Given this list of marker genes ISL1, P2RY1, CPA3, CYP2C18, CYP1B1, GCG, CYP2D6, PLA2G6, SLC8B1, H6PD, ADCY5, FFAR4, HSD3B2, SOX8, GNA11, MPC2, AGT, BBS1, HTR2C, CRY1, AIMP1, SNX19, C1QTNF12, CFTR, DGAT1, NIBAN2, TM7SF3, PER2, PLEKHA1, HSD17B2, CAMK2G, HID1, CHST10, CPE, BMP2, WNK4, SIRT3, CELA2A, VAMP8, TRPM5, GLUD1, HSD17B6, TRPA1, OXCT1, CHRM3, CGA, RAB11FIP5, RDH14, KCNQ1, KLK6, SIDT2, GCNT4, UGT2B17, GALR1, CDK16, TIPARP, LRP5, LHCGR, GNAO1, FOXE1, NOS2, DHRS9, KCNK9, FGFR1, TARDBP, ADH6, APLN, PCSK4, LEP, ASMT, CLCN2, LRRC8A, SNX4, TMF1, PDE8B, PCSK5, NDST2, MAFA, POMC (NCBI Gene Id 5443), FOXA2, GIP, SHH, HSD17B10, HSD17B3, SLC5A5, HSD17B4, AFP, ALDH8A1, EPHA5, DHRS2, ARNT, ITSN1, RDH12, GPLD1, SLC17A4, RBP4, PDX1, UGT1A3, UGT1A9, WNT4, SLC7A8, UGT1A1, OSBP, DIO2, CTSB, RDH8, MBOAT4 (membrane bound O-acyltransferase domain containing 4), AGTR1, TUNAR, PAX8, ATP1A1, NMU, ANO1, PPARG, C2CD2L, RPH3AL, RAPGEF3, SLC2A2, DIO1, GNAS, DUOX2, SLC16A1, EDN3, PASK (PAS domain containing serine/threonine kinase), ACVR2B, TUBB1, IL4I1, PPARD, CYP11B2, ZMPSTE24, IL1B, SULT1A3, ORAI1, SNAP25, RBM4, AKR1B15, CYP11A1, KCNB1, ZBED6, GRP, DAB2, NMB, RPE65, PCLO (piccolo presynaptic cytomatrix protein), RAF1, BRSK2, SPP1, REN, STXBP3, OSM, GPR27, NKX3-1, UQCC2, NPVF, CEL, HSD17B8, BMP5, STC2, STXBP4 (syntaxin binding protein 4), CHST8, RFX6, PCSK1, ABCA12, EIPR1, DOC2B, GPR68, PLB1, NLGN2, VAMP2, CYB5R4, TRPV6, PRLHR, MIDN, SULT1E1, PFKFB2, GHRH, FFAR1, C1QTNF1, CYP3A4, CORIN, IL1RN, ESR1, NR1H4, TACR2, CYP2C8, ADRA2C, CHGA, HADH, MTNR1B, RAB1A, CYP19A1, SCNN1B, SCG5, CTSK, SLC16A10, FFAR3, PARK7, AKR1C1, NKX6-1, TCIRG1, RETN, F2RL1 (NCBI Gene Id 7901, F2R like trypsin receptor 1), TFAP2B, CAPN10, BCO1, CPA4, STX1A, JAGN1, FOXO1, C1QTNF3, HNF4A, EDN1, HSD17B12, OPRK1, INS, MLXIPL, HTR1A, RASL10B, ADH1C (NCBI Gene Id 126), DHRS3, PLA2G3, DPP4, NAGLU, UCN3, SELENOM, RAB11FIP3, ADIPOQ, PHPT1, VSNL1, SMAD2, AQP1, CYP46A1, PTPRN2, TPO, RDH5, TAC1, BMAL1, STAT5B, HNF1B, DUOXA1, ADRA2A, CTSG, SULT1A1, SIRT6, PNLIP, GJA1, PCSK1N, BCO2, GHSR, SLCO1B1, FSHB, KCNK16, NADK, ERO1B, ALDH1A3, HNF1A (HNF1 homeobox A), STX4, SRD5A2, LTBP4, LIPE, IFNG, RDH11, FGF23, PLCB1, CYP2W1, BMP6, CYP1A1, GIPR, SULT1A4 (sulfotransferase family 1A member 4), G6PC2, VAMP3 (vesicle associated membrane protein 3), DHRS11, HSD17B7, CYP26C1, DUOX1, NR3C1, MEP1A, BAD, FGG (fibrinogen gamma chain), CYP21A2, SERP1, INHBB, ILDR1, BCHE, JAK2, UGT2B11 (NCBI Gene Id 10720), CYP17A1, AKR1C4, TRPM4 (transient receptor potential cation channel subfamily M member 4), SLC39A14, CYP26B1, TSPO, PPP3CB, SGPL1, MYB, UGT1A7, PRKACA, TFR2, PICK1, AKR1B10, ECE1, HMGA2, SDR16C5, POR, TACR1, DUOXA2, UCN, SIRT4, CCDC186, CYP3A5, VGF, HSD17B11, INHA, CLTRN, TBX3, TCF7L2, SRD5A1, RAB3A, PFKM, PRCP, NR5A2, SLC26A7, BAIAP3, NDUFAF2, ILDR2, GNAZ, SNAP23 (NCBI Gene Id 8773), CYP26A1, RDH16, MME, ADM, REST, SULT1B1, UGT2B10, SMAD4, SOX4, CD38 (CD38 molecule), UGT2B4, RETSAT, KLF7, CYP27C1, VIP, UGT2B7, CRYM, CYP2C9, FKBP1B, FOXD1, FGB, SLC16A2, STARD3, RAC1, ADAM10, DIO3, UGT1A8, FAM3D, SYT7, KCNJ11, PCSK2, GCK, HFE, GABBR1, LIF, NR0B2, ECRG4, AANAT, FAM3B, ADCY8, GPR119, SELENOT (NCBI Gene Id 51714), HCAR2, SLCO4A1, ALDH1A2, CTSZ, RAB11B, GHRHR, AWAT2, SIN3A, PRKN, MCU, IDE, RAB11FIP1, CRABP2, AKR1B1, ADH7, IYD, LYN, NR1D1, CHD7, DISP1, PRMT3, RIMS2, AKR1C2, NEUROD1, AKR1D1, SNX6, INHBA, PIM3 (Pim-3 proto-oncogene, serine/threonine kinase), TOR2A, EGR1, NR5A1, ATP6AP2, RDH13, ADORA1, SCT, SYTL4, PNPLA4, ACSL4, F2RL2, PNPLA2, BMP8A, PCSK6, SULT2A1, CLOCK (clock circadian regulator), SLC25A22, EDNRB, UCP2, CCL5, ECE2, DGKQ, SOX11, LHB, HLA-DRB1, DHRS7, ALDH1A1, CRY2, PRKD1, SLCO1C1, DKK3, GNB3, NPFF, BCAT2, VAMP7, PAPSS2, SLC30A5 (solute carrier family 30 member 5), RDH10, ENPEP, AACS, CCN3, EFNA5, SREBF1, HSD17B1, PREP, IL11, CPLX3, CYP11B1, PRKCB, SYBU, UGT2B15, P4HB, CTSL, AKR1C3, F2, TRH, CRHBP, ANPEP, DHRS4, SCPEP1, SMPD3, CMA1 (NCBI Gene Id 1215), FSHR, PRKCA, DRD2, SLC7A5, BACE2, UBE2Q1, PSMD9 (NCBI Gene Id 5715), CRHR1, TG, SLC3A2, CYP2S1, MYRIP, ADH1B, FOXA1, FURIN, PCSK7, STUB1 (NCBI Gene Id 10387), ADCYAP1, HSD3B1, MC4R, CCKAR, SLC22A9, FGA, ACVR1C, EXOC3L1, BTK, HPN, YIPF5, NNAT, ADH1A, GAL, FOXL2, DGAT2, PTPRN, CRH, PRKAR1A, SLC9B2, LRAT, IL6, IRS2, ENY2, KCNA5, RFX3, ADH4, PTPN11, KDM5B, RAPGEF4, GPER1, TRPV4, RAB11FIP2, ABCC8, ITPR1, SDR9C7, SLC30A8, ACE, CARTPT, PFKL, SSTR5, GPRC6A (G protein-coupled receptor class C group 6 member A), PDGFRA, BLK, SCP2, GNRHR, DDO, ANXA1, FFAR2, CPLX1 (complexin 1), DYNLL1, RAB8B, SRI, CPQ, GHR, FDX1, FZD4, PLA2G7, SRD5A3 (NCBI Gene Id 79644), IRS1, CREB1, TNFSF11, GDF9, CPT1A, ABAT, UGT2B28, PRKCE, CASR, HIF1A, RBP1, GNAI1, CYP3A7, ENSA, ACE2, PCK2, MED1, RAB44, TNF, CHST9, CYP1A2, ABCB1, FAM3A, CACNA1H, ALOX5, GLP1R, SERPINA7, SLC18A2, GATA3, GHRL, here is a description of the gene set: studied in species Homo sapiens Human Gene Set: GOBP_REGULATION_OF_HORMONE_LEVELS Any process that modulates the levels of hormone within an organism or a tissue. A hormone is any substance formed in very small amounts in one specialized organ or group of cells and carried (sometimes in the bloodstream) to another organ or group of cells in the same organism, upon which it has a specific regulatory action.